Given this list of marker genes TIPARP, IFIH1, DTX3L, UNC93B1, NFE2L1, USP11, SAMD9, ROPN1L, TNFSF10, ZCCHC2, GTPBP1, TOR1B (NCBI Gene Id 84822), CD38, RP2, PLSCR2, OSBPL2, EIF2AK2, MS4A6E, NT5C3A, CIMAP1B, WDFY1, B3GNT2, TUBB2A, HTR2B, CLIC1, SLFN12, STAT2, DRAP1, ELF1, KDM6A, CCNA1, ELMO2, OAS2, NCOA7, OAS3 (2'-5'-oligoadenylate synthetase 3), ISG20, CRYBG1, OAS1, TM2D3, PARP10 (poly(ADP-ribose) polymerase family member 10), CXCL11, IFITM2, IFI16, GTF2B, C19orf25, TRIM56, ISG15, IRF2, DYNLT1, EPSTI1, PRKAG2, SP100, UBE2F (ubiquitin conjugating enzyme E2 F (putative)), ARL8A, IRF9, IRF7 (interferon regulatory factor 7), ZBP1, STAP1 (signal transducing adaptor family member 1), AP1G2, PARP12, GMPR, ZBTB43, ARMCX1, DHX58, AMOTL2, RHEB, TRAFD1, IFIT5, RIGI, TENT4A, TDRD7, PLSCR4, CFB, PHF11, NABP1, TMEM60, NCSTN, TRIP4 (NCBI Gene Id 9325), CNDP2, KIAA0040, IFI44, BST2, SAT1, PARP4, IFIT2, UBE2L6, PELI1, LGALS9 (galectin 9), TMEM187, AFG1L, DUSP5, NOD1, TRIM21, SLC25A28, CHST12, OASL, RRAGC (Ras related GTP binding C), MYD88, NMI, CDKN1C, RAB5IF, PHACTR4, LY6E, MLKL, IFITM1, TRIM25, XAF1, KHNYN, ZNFX1, RBM7, IFI27, TMEM268, CMTR1, SHFL, ETV7, C21orf91, CTTNBP2, CCNK, PLSCR1, SUPT3H, INAFM1, GIMAP6, DCTN4, RAD9A, FEZ2, OPTN, CXCL10, ARHGAP27 (Rho GTPase activating protein 27), BARD1, RNF175, MICB, SLC37A1, GSTK1, RHEBL1, TRPC4AP, PTGER4, MOV10, TENT5A, CAPN2, CHMP5, GCM2, HESX1, SP110, USP25, C1GALT1, FBXO7, TREX1, AIFM2, ARHGEF3, AZI2 (5-azacytidine induced 2), NAPA, SHISA5, SPTLC2, SAMD9L, GNG5, ENPP2, BLZF1, B4GALT5, IFI35, MNDA, BLVRA, RAB8A, TRIM26, NUB1 (NCBI Gene Id 51667), FBXO6, CALCOCO2, ZNF233, ELF4, IFITM3, C4orf33, CNPPD1, LAP3 (NCBI Gene Id 5186), GIMAP4, SPATS2L, SMCHD1, DDX60, IRF8 (NCBI Gene Id 3394), LAMP3, CDS2, VRK2 (NCBI Gene Id 7444), IFI44L, KANSL3, STOM, GCH1, PARP9, IL15RA, NRBP1, SH3GLB1, MX2, HELZ2, DOP1A (NCBI Gene Id 285787), SNW1, PPM1K, SAP30BP, here is a description of the gene set: Th1 and Th2 cells arise from a common precursor cell in response to triggering through the TCR and cytokine receptors for IL-12 or IL-4. This leads to activation of complex signaling pathways, which are not known in detail. Disturbances in the balance between type 1 and type 2 responses can lead to certain immune-mediated diseases. Thus, it is important to understand how Th1 and Th2 cells are generated. To clarify the mechanisms as to how IL-12 and IL-4 induce Th1 and Th2 differentiation and how TGF-beta can inhibit this process, we have used oligonucleotide arrays to examine the early polarization of Th1 and Th2 cells in the presence and absence of TGF-beta after 0, 2, 6 and 48 hours of polarization. from publication Lund R, Aittokallio T, Nevalainen O, Lahesmaa R (PMID 14607935) studied in species Homo sapiens Genes down-regulated in CD4 T cells activated by anti-CD3 and anti-CD28: TGFB1 and IL4 (2h) versus untreated (2h). Human Gene Set: GSE2770_TGFB_AND_IL4_ACT_VS_ACT_CD4_TCELL_2H_DN